The following is a description of a gene set: Mouse Gene Set: GOBP_REGULATION_OF_TRANSLATION_AT_SYNAPSE_MODULATING_SYNAPTIC_TRANSMISSION Any process that modulates synaptic transmission by regulating translation occurring at the synapse. species: Mus musculus, and this is the list of marker genes: Fxr1, Fxr2, Eif4e, Eif4a3, Fmr1, Mtor, Eif4a3l2, Eif4a3l1, Cpeb2, Cpeb1, Cyfip1